Given this list of marker genes SAAL1, BTK, NEAT1, MIR181C, TNF, here is a description of the gene set: species: Homo sapiens The multiplication or reproduction of type B synoviocytes by cell division, resulting in the expansion of their population. A type B synoviocyte is a fibroblast-like cell found in synovial tissues. Human Gene Set: GOBP_SYNOVIOCYTE_PROLIFERATION